Given this list of marker genes TK1, PMVK, CUL4B, HAT1, SPOCK2, APOBEC3B, MICA, TRAC, NFASC, SOCS6, GSS, RNASE6, PRF1, SERPING1, CIR1, RBBP8, SORL1, LAPTM4B, SH3BP5, CA3, LST1, here is a description of the gene set: To elucidate the genomics of cellular responses to cancer treatment, we analyzed the expression of over 9,600 human genes in acute lymphoblastic leukemia cells before and after in vivo treatment with methotrexate and mercaptopurine given alone or in combination. Based on changes in gene expression, we identified genes that accurately discriminated among the four treatments. Discriminating genes included those involved in apoptosis, mismatch repair, cell cycle control and stress response. Only 14% of genes that changed when these medications were given as single agents also changed when they were given together. These data indicate that lymphoid leukemia cells of different molecular subtypes share common pathways of genomic response to the same treatment, that changes in gene expression are treatment-specific and that gene expression can illuminate differences in cellular response to drug combinations versus single agents. Human Gene Set: CHEOK_RESPONSE_TO_MERCAPTOPURINE_DN Genes specifically down-regulated in pediadric acute lymphoblastic leukemia (ALL) patients by mercaptopurine. from publication Cheok MH, Yang W, Pui CH, Downing JR, Cheng C, Naeve CW, Relling MV, Evans WE (PMID 12704389) species: Homo sapiens